The following is a description of a gene set: The aggregation, arrangement and bonding together of a set of components to form the spindle, the array of microtubules and associated molecules that serves to move duplicated chromosomes apart. studied in species Mus musculus Mouse Gene Set: GOBP_SPINDLE_ASSEMBLY, and this is the list of marker genes: Gpsm2, Racgap1, Hspa1a, Cdca8, Flna, Cenpe, Dcaf13, Lzts2, Abraxas2, Smc1a, Cep63, Bcas2, Mapre1, Map9, Kash5, Cltc, Sass6, Rab11a, Pibf1, Chmp3, Cenpj, Mzt1, Tubb5, Hspa1b, Gtf2b, Tubgcp3, Chmp1b, Ofd1, Misp, Septin1, Chmp5, Tubgcp2, Spag5, Chmp1a, Haus7, Prc1, Sac3d1, Zfp207, Poldip2, Tpr, Rps3, Spice1, Tpx2, Bccip, Chmp2b, Haus6, Ino80, Wrap73, Ndc80, Eml3, Stag2, Chmp7, Mapre3, Mapre2, Washc5, Haus5, Ddb1, Haus2, Kif3b, Haus1 (NCBI Gene Id 225745), Ccnb2, Ccdc66, Vps4b, Rnf4, Kifc5b, Kif4, Uhrf1, Aspm, Numa1, Ppp2r1a, Birc5, Tubgcp6, Prickle1, Mlh1, Clasp1, Rcc1, Washc1, Stag1, Kifc1, Fbxo5, Nek2, Chmp2a, Ripor2, Golga2, Rhoa, Khdc3, Haus3, Tubgcp5, Cep192, Incenp, Csnk1d, Kif11, Haus8, Mybl2, Kif2a, Ccdc69, Drg1, Ccsap, Ncor1, Chek2, Ppp2r1b, Ska2, Chmp4b (charged multivesicular body protein 4B), Abraxas1, Cdc20, Rangrf, Cep97, Haus4, Mapk15, Snhg15, Plk1, Hdac3, Chmp4c, Pten, Kpnb1, Tubb1, Senp6, Aurka, Chmp1b2, Dync1h1, Ska3, Ska1, Tubgcp4, Kif15, Stil, Dicer1, Ccdc61, Aurkb, Aaas, Map10, Chmp6, Arhgef10, Lsm14a, Stard9, Clasp2, Kif23, Hnrnpu, Smc3